Given this list of marker genes Crhr1, Ms4a2, Itgb2l, Il4, Il4ra, Itgb2, Lypd10, Nppc, Syk, Sphk2, F2rl1, Fcer1a, Pld2, Gata1, Adora3, Lamp1, Ptafr, Itgam, Stx4a, Stxbp1, Gab2, Vamp8, Cd160, Snx4, Adora2b, Fcer1g, Lypd11, Fgr, Stxbp2 (syntaxin binding protein 2), Il13 (NCBI Gene Id 16163), Ap1g1, Cd177, Gata2, Nppa, Pla2g3, here is a description of the gene set: studied in species Mus musculus Mouse Gene Set: GOBP_POSITIVE_REGULATION_OF_LEUKOCYTE_DEGRANULATION Any process that activates or increases the frequency, rate or extent of leukocyte degranulation.